Given this list of marker genes PBX4, RIC3 (RIC3 acetylcholine receptor chaperone), TTC14, DNALI1, NKIRAS2, ESCO1, CABLES2, ZNF80, TEF, ZNF705D, MFHAS1, RASGRP1, PTPRD, IKZF3, SAA2 (NCBI Gene Id 6289), FIGNL2, COL6A1, ZNF705EP, CBFA2T3, KXD1, SEMA3A, ARF1, VAV3, RCAN2, RCOR1, CYSLTR1, MFSD8, COPS3, SEMA4D (semaphorin 4D, NCBI Gene Id 349236), ZNF608, BMPR2, TET1, ARFGEF2, CDYL, AADAC, CYB5A, ANGPT4, GXYLT1, TRAK2 (NCBI Gene Id 66008), STON1, PEAK1, CCPG1, UVRAG, ACVR2A, PAX6, TOMM40L, DFFA, SUCLA2, ARID1A, ERCC6, PSKH1, KCTD2, RASSF6, ACVR2B, TMEM52B, CASTOR2, SFXN5, THAP1, PRR16, AAK1, ADAMTS15, NALCN, PRKCA, MIOS (meiosis regulator for oocyte development), FGF14, APOBEC3A (NCBI Gene Id 91577), CYRIA, PATJ, MARCHF6, USP38, FRK, ANGPTL4 (angiopoietin like 4), PIP4K2C, RAG1, DLK1, KIF27, KCNA3, NAV2, CAPS2, MRRF, SLC2A13, PPP1R9A, ERLIN2 (NCBI Gene Id 140906), TET3, NFATC3, YOD1, CD300LF, POLK, PGR, GLO1, SPECC1, GIN1, RHOT1, SRSF6, ARID3B, NRIP1, KCNH1, PCYT1A, DDHD1, PPM1F, SPRED3, CAPS, RHOQ, RUNX1T1, CLEC1A (NCBI Gene Id 51267), HOXA1, RAMAC, SLAMF6, ZNF233, LINC02688, UHMK1, ZNF705A, OPHN1, HSPA14, PAX5, NXF1, SLC25A26, CSRP3, WASF2, FAM177B, ZNF626, DUSP16, SERP1, KIAA0040, ERC2, LCK, RUNX1, SRGAP3, VCL, MOCS1, CCND2, RGS19, BAZ2B, USP36, RGS1, RBFOX1, SENP2, GPD1, TTC17, KLK4, KANSL3, CCER1, MMP28, SH2B3, ZFYVE26, MXD1, RFT1, ADAM10, QKI, RAB8B (NCBI Gene Id 51762), RALGPS1, RPRD1B, HOXC10, EXPH5, MYEOV, ESRP1, LGR5, LRRC8A, LRIG2, SPATA12, BEGAIN, ADGB, UTRN, PPP2R3C (protein phosphatase 2 regulatory subunit B''gamma), SLCO1A2, IKZF2, TIMP2, RAB3C, RB1, URB2, ARMC8, ZMIZ2 (NCBI Gene Id 83637), CDNF, PRDM5, VNN1, GNB1, SRC, ZKSCAN8, TRAF6, XPO7, GALNT15, COL4A6, ZBTB41, CPEB4, MTMR9, here is a description of the gene set: from publication Chen Y, Wang X (PMID 31504780) Genes predicted to be targets of miRBase v22 microRNA hsa-miR-12119 in miRDB v6.0 with MirTarget v4 prediction scores > 80 (high confidence targets). Human Gene Set: MIR12119 studied in species Homo sapiens